The following is a description of a gene set: studied in species Mus musculus Mouse Gene Set: REACTOME_RUNX3_REGULATES_WNT_SIGNALING RUNX3 regulates WNT signaling, and this is the list of marker genes: Ctnnb1, Tcf7, Tcf7l2, Tcf7l1, Runx3, Lef1